Given this list of marker genes SLC4A4, SLC39A14, SLC39A12, SLC26A9, SLC4A8, SLC4A7, SLC26A1, SLC26A4, SLC39A6, SLC39A4, SLC4A1, SLC26A3, SLC39A5, SLC39A8, SLC26A5, SLC4A10, BEST2, SLC4A3, SLC26A6, SLC4A5, SLC26A8, SLC4A11, BEST1, SLC26A2, CFTR, SLC26A7, BEST4, SLC4A2, SLC39A10, SLC26A11, SLC4A9, SLC26A10P, here is a description of the gene set: Human Gene Set: GOMF_BICARBONATE_TRANSMEMBRANE_TRANSPORTER_ACTIVITY species: Homo sapiens Enables the transfer of bicarbonate from one side of a membrane to the other. Bicarbonate is the hydrogencarbonate ion, HCO3-.